Given this list of marker genes HAVCR2, HLA-DRB1, BMP6, SCARB2, IFNG, FTH1, KCNN4, STX11 (NCBI Gene Id 8676), CPOX, HMOX1, SLC4A1, PSMB9, SLC7A7, UNC13D (unc-13 homolog D), PUS1, ALK, SLC25A38, PIGA, IFT56, PHOX2B, PKLR, LACC1, CP, BMP2, ITK, SLC30A10, PIK3CG, IL6, IFIH1, MPV17, HACE1, GLRX5, FTL, STXBP2, MYCN, BCS1L, SLC40A1 (NCBI Gene Id 56414), MIF, MCM10, HAMP, LMO1, NLRC4, SLC19A1, GBA1, LIN28B, KARS1, TFR2, STAT2, LYST (lysosomal trafficking regulator), HFE, HJV, GFER, PIEZO1 (piezo type mechanosensitive ion channel component 1 (Er blood group)), PRF1, HBB, STAB1, XIAP, FOCAD, STEAP3, here is a description of the gene set: Human Gene Set: HP_ABNORMAL_CIRCULATING_FERRITIN_CONCENTRATION species: Homo sapiens Abnormal circulating ferritin concentration A deviation from the normal circulating concentration of ferritin. Ferritin concentration can be measured in serum or plasma.